Given this list of marker genes Acadm, Gnai2, Arpc1b, Gbp2, Foxn3, Galnt7, Csrp1, Nr4a3, Ggta1, Samhd1, Fscn1, Necap2, Acsl5, Tspan13, Slc27a3, Cnn2, Macroh2a1, Pde1b, Eif4a1, Pik3r5, Ccnd2, Jak2, Cd86, Nup88, Eif3a, Myadm, Orai1, Arpc5, Prkcd, Trip12, Batf3, Cyfip1, Stxbp6, Grk2, Grk3, Rbms1, Rexo2, S100a10, Nfkb1, Nap1l1, Map3k14, Myo1g (NCBI Gene Id 353209), Rap2a, Iqgap1, Cxcl9, Crispld2, Bcl2a1d, S100a11, Glipr2, Coro2a, Tuba1a, H2-Eb1, Pdlim5, Tagln2, Efhd2, Sh3bgrl, Anxa2, Sirpa, Adcy6, Ywhah, Ndrg1, Tubb2b, Tap2, Irf5, Gbp5, Ccl22, Itga4, Arpc2, Pirb, Cfl1, Gpr183, Filip1l, C1qbp, Gpx1, Plgrkt, Cytip, Tubb2a, Syngr2, Zbtb18, Bcl2a1b, Adprh, Vopp1 (vesicular, overexpressed in cancer, prosurvival protein 1), Vim, Gnb2, Scamp2, Cd74, Ctsz, Ehd1, Aldh1a2, Cst3, Mllt6, Nckap1l, Lima1, Plac8, Pdcd1lg2, Psen2 (NCBI Gene Id 98295), Rnf115, Cd274, Eif5a, Diaph1, Pias3, Rbx1, Foxn2, Fcgrt, Rogdi, Tnfrsf9, Wipf1, Capzb, Adgre5, Fabp5, Ifitm2, Atrx, Tbc1d8, Jaml, Rabgap1l, Snd1, Serpina3g, Gpbp1, Gnai3, Tes, Fmnl1 (NCBI Gene Id 77175), Selplg, Bcl2a1a, Zfand6, Napsa, Ikzf4, Ccl17, Ahnak, Il10ra, H2-Aa, Peli1, Gyg1, Cdkn1a, Litaf, Ptpn1, Cd48, Myl12a, Mir155hg, Cish, Actg1, Ass1, Eloc, Pfn1, Dusp5, Pkib, Csf2rb, Cd1d1, Mob3a, Relt, here is a description of the gene set: Cytokines mediate cell-cell communication in the immune system and represent important therapeutic targets. A myriad of studies have highlighted their central role in immune function, yet we lack a global view of the cellular responses of each immune cell type to each cytokine. To address this gap, the authors created the Immune Dictionary, a compendium of single-cell transcriptomic profiles of more than 17 immune cell types in response to each of 86 cytokines (>1,400 cytokine-cell type combinations) in mouse lymph nodes in vivo. A cytokine-centric view of the dictionary revealed that most cytokines induce highly cell-type-specific responses. For example, the inflammatory cytokine interleukin-1β induces distinct gene programmes in almost every cell type. A cell-type-centric view of the dictionary identified more than 66 cytokine-driven cellular polarization states across immune cell types, including previously uncharacterized states such as an interleukin-18-induced polyfunctional natural killer cell state. Genes positively differentially expressed in cell type: MigDC (migratory dendritic cell) upon treatment with cytokine: IL-3 in mouse lymph nodes in vivo. studied in species Mus musculus Mouse Gene Set: CUI_MIGDC_IL3_RESPONSE_UP from publication Cui A, Huang T, Li S, Ma A, Pérez JL, Sander C, Keskin DB, Wu CJ, Fraenkel E, Hacohen N (PMID 38057668)